Given this list of marker genes Scml4, Anxa11, Dennd1a, Gata2, Atpsckmt, Cntn4, Tmem38a, Dcun1d3, Slc24a2, Atrn, Cited2, Rpl15, Tln2, Fam76a, Pvalb, Rnf149, Adcy1, Lrtm1, Zfp644, Ncoa7, Rhobtb2, Anks3, Gsk3a, Dgkd, Brd8, Depdc7, Prrc2b, Ube2z, Dbr1, Atf7, Hbp1, Tef, Tspan11, Creb1, Trit1, Lmx1a, Dennd1b (DENN domain containing 1B), Mcf2l, Ccdc136, Mllt6, Gys1, Afdn, Rassf3, Mtmr10, Sim1, Unc80, Sox5, Lhfpl4, Zc3h10, Natd1, Sertad3, here is a description of the gene set: Genes predicted to be targets of miRBase v22 microRNA mmu_miR_7069_3p in miRDB v6.0 with MirTarget v4 prediction scores > 80 (high confidence targets). from publication Chen Y, Wang X (PMID 31504780) studied in species Mus musculus Mouse Gene Set: MIR_7069_3P